Given this list of marker genes Oxt, Ncoa2, Esp1, Thra, Vmn2r116, Ncoa1, here is a description of the gene set: studied in species Mus musculus Mouse Gene Set: GOBP_POSITIVE_REGULATION_OF_FEMALE_RECEPTIVITY Any process that activates or increases the receptiveness of a female to male advances.